Given this list of marker genes Slc6a11, Htr1b, Apba1, P2rx7, Nherf1, Ntsr1, Slc32a1, Hrh3, Slc6a6, Best1, Htr1a, Gabbr1, Slc6a12 (solute carrier family 6 (neurotransmitter transporter, betaine/GABA), member 12), Pak1, Trpc4, Htr6, Slc7a14, Slc6a13, Cacna1a, Slc6a1, Grik1, Abat, Htr2c, Nf1, Trh, Cacnb4, Sv2a, here is a description of the gene set: species: Mus musculus The directed movement of gamma-aminobutyric acid (GABA, 4-aminobutyrate), an amino acid which acts as a neurotransmitter in some organisms, into, out of or within a cell, or between cells, by means of some agent such as a transporter or pore. Mouse Gene Set: GOBP_GAMMA_AMINOBUTYRIC_ACID_TRANSPORT